Given this list of marker genes DIMT1, DSCAML1, CAPN10, ARHGAP31, CKB (creatine kinase B), BLOC1S4, USP24, CLCN5, UBE2G1, TMEM128, OVOL2, FMR1, TMED7, PDF, TIMM23, MRPS6, HCK, PPT2, ID3, PIGM, FAM76A, ETAA1, HOXA5, MANF, OTUB1, CAPN8, MAPK8, RCN2, ATP2C1, DDX54 (NCBI Gene Id 79039), ALYREF, PSME3, AZIN1, ACTR1B (actin related protein 1B), UBE2E2 (ubiquitin conjugating enzyme E2 E2), PILRA, SEMA4A, CCT6A, GABRB1, GUCA1A, KRTAP4-12 (keratin associated protein 4-12), UBE2I, SCX, RNF145, SARNP, CSF1 (colony stimulating factor 1), CDK11B, LIN7C, MRPL50, STX4, SELENOS, TM9SF4, PITX3, KCTD4, FEM1A, TRIB1, CBLL1, RRP15, SLC34A2, IPO5, EEF1E1, PHYKPL, IER5, ICOS, P2RY14, FAM20C, SIX1, TMEM9B, SSBP3, CD200 (CD200 molecule), GCM2, MAP4K5, MYH6, ABCD3, DHX40, IYD, KYAT3, ABCG2, ACSL5, ELF5, HBS1L, SLC25A42, RRN3, SIRT4, ELOVL1, DHPS, APPBP2, NLRP3, NUP160, WASHC2A, RILPL2, PSMD7, SDC4, RAB11B (RAB11B, member RAS oncogene family), HSPA1B, ATOSB, CDH6, BUD31, HERC2, KCNQ1, LRRK2, C18orf32, RFFL, CCR8, IL4I1, MDM2, CDC25A, LMBRD1, PEA15, RDH10, LRRC59, CHID1, GPR153, LY75, RAB10 (NCBI Gene Id 51140), TMEM243, NOC3L, PKP4, SMAD2, GAS7, USP47, RHBDF1 (rhomboid 5 homolog 1), CCNB1IP1, JPH2, ITGB1, FSCN1, NUS1, EIF3J, FOXJ1, RPS27L, MEIS1, UBXN8, GMFG, TLR7, COG2, ADAM17, MT1E, DHX8, IRX3, TMEM120B, PANK3, FOXF1 (forkhead box F1), SRSF1, AOAH, HEATR6, VTA1, SEL1L, CSTB, CTSK, C21orf91, CD247, SLC6A20, SRSF7, CDO1, POLR3D, TSR1, SLA, NCK2, WDR48, TNFAIP3, FIS1, MOGAT1, CD72, STARD4, LYAR, CD9, GPR84, SIGLEC7, ARMCX3, PRELID3A, ATP2A3, ZNF334, NRAP, VCAN (NCBI Gene Id 7902), CTTN, C2orf76, HADHA, CCNB3, PTGES, NSMF, BRAF, POLM, TACR3, LCN2, CPEB4, PBX3, SLC25A25, DNAJA2, MAN2A1, IL17RA, RALB, PPP1R42, ABHD16A, TRMT1L, AKT3 (AKT serine/threonine kinase 3), CA13, HINFP, UBE2A, IL36A, LCP2, here is a description of the gene set: from publication Amit I, Garber M, Chevrier N, Leite AP, Donner Y, Eisenhaure T, Guttman M, Grenier JK, Li W, Zuk O, Schubert LA, Birditt B, Shay T, Goren A, Zhang X, Smith Z, Deering R, McDonald RC, Cabili M, Bernstein BE, Rinn JL, Meissner A, Root DE, Hacohen N, Regev A (PMID 19729616) Human Gene Set: GSE17721_POLYIC_VS_CPG_4H_BMDC_DN studied in species Homo sapiens mouse primary BMDCs were stimulated with tlr ligands and gene expression changes were profiled on Affymetrix arrays Genes down-regulated in comparison of dendritic cells (DC) stimulated with poly(I:C) (TLR3 agonist) at 4 h versus DC cells stimulated with CpG DNA (TLR9 agonist) at 4 h.